Given this list of marker genes Phkg1, Phkb, Adcy10, Adra1b, Hmgb1, Phka1, Phkg2, here is a description of the gene set: Any process that activates or increases the frequency, rate or extent of the chemical reactions and pathways resulting in the breakdown of glycogen. Mouse Gene Set: GOBP_POSITIVE_REGULATION_OF_GLYCOGEN_CATABOLIC_PROCESS studied in species Mus musculus